Given this list of marker genes Hdgfl2, Fgf2, Cbx5, Cbx2, Kdm4c, Dpf2, Cbx7, here is a description of the gene set: studied in species Mus musculus Mouse Gene Set: GOMF_HISTONE_H3K9ME2_3_READER_ACTIVITY A histone reader that recognizes a histone H3 trimethylated at lysine 9. In some organisms, there is only H3K9me2, not H3K9me3, but this modification is recognized by homologous readers.